Given this list of marker genes NPHP3, IFNG, GANAB, TSC1, ALG8, CC2D2A, IFT140, WDR19, DNAJB11, LRP5, ALG5, IFT122, EXTL3, NEK8 (NIMA related kinase 8), PKD1, ALG9, TTC21B, SEC63 (SEC63 homolog, protein translocation regulator), TSC2, PKD2, BICC1, PKHD1, OFD1, JAK1, here is a description of the gene set: Human Gene Set: HP_HEPATIC_CYSTS species: Homo sapiens Hepatic cysts